Given this list of marker genes MIR520C, MIR144, MIR506, IL1B, CAV1, here is a description of the gene set: Human Gene Set: GOBP_POSITIVE_REGULATION_OF_CELL_ADHESION_MOLECULE_PRODUCTION studied in species Homo sapiens Any process that increases the rate, frequency or extent of cell adhesion molecule production. Cell adhesion molecule production is the appearance of a cell adhesion molecule as a result of its biosynthesis or a decrease in its catabolism.